The following is a description of a gene set: Human Gene Set: GOBP_OSTEOCLAST_DIFFERENTIATION The process in which a relatively unspecialized monocyte acquires the specialized features of an osteoclast. An osteoclast is a specialized phagocytic cell associated with the absorption and removal of the mineralized matrix of bone tissue. studied in species Homo sapiens, and this is the list of marker genes: INPP5D, IGSF23, SLC4A2, DCSTAMP, RASSF2, TNF, IFT80, GPR137B, IL23R, IL17A, CCN4, ANXA2, FOXP1, TMEM64, IL20, SBNO2, FOS, SIGLEC15, CREB1, MTOR, GPR55, GPC3, ATP6AP1, CEBPB, POU4F1, NEDD9, EPHA2, CARTPT, SRC, SPI1 (Spi-1 proto-oncogene), TNFRSF11B, LTF, JUNB, NF1, CSF1, CD81, TNFRSF11A, TOB2, UBASH3B, TFRC, CD109, GPR137, TNFSF11, MAFB, TLR4, OSTM1, TYROBP, ERFE, GLO1, TGFB1, TRAF6, TREM2 (NCBI Gene Id 54209), CTNNB1, PAFAH1B1, MAPK14, PRXL2A, LILRB3, BGLAP, BMP2, FAM20C, KLF10, GPR68, IAPP, TM4SF19, PPARGC1B, P2RX5, TNFAIP6, CCR1, OSCAR, PIK3R1, IREB2, FBXW7, SLC9B2, FSTL3, BBLN, CLDN18, PIAS3, NOTCH2, TCTA, SH3PXD2A, TCIRG1, FSHB, IL12B (NCBI Gene Id 7907), TFE3, FCER1G, EEIG1 (estrogen-induced osteoclastogenesis regulator 1), OCSTAMP, FBN1, FARP2, LILRB1, IL4, TLR3, IL23A, ZNF675, SNX10, GAB2, GPR183, FOSL2, CAMK4, TMEM178A, RPTOR, CSF1R, LRRK1, IFNG, FSHR, CALCA, CALCR, TF, EFNA2, SFRP1, MITF, PPP3CA, POU4F2, LILRB4, CCL3, LRRC17